Given this list of marker genes Spint1, Hpn, Hgfac, Hgf, here is a description of the gene set: studied in species Mus musculus Reactome Pathway: MET Receptor Activation part of: Signaling by MET electronically inferred by orthology from the curated human pathway This event has been computationally inferred from an event that has been demonstrated in another species.<p>The inference is based on the homology mapping from PANTHER. Briefly, reactions for which all involved PhysicalEntities (in input, output and catalyst) have a mapped orthologue/paralogue (for complexes at least 75% of components must have a mapping) are inferred to the other species.